The following is a description of a gene set: Mouse Gene Set: GOBP_MULTIVESICULAR_BODY_SORTING_PATHWAY A vesicle-mediated transport process in which transmembrane proteins are ubiquitylated to facilitate their entry into luminal vesicles of multivesicular bodies (MVBs); upon subsequent fusion of MVBs with lysosomes or vacuoles, the cargo proteins are degraded. studied in species Mus musculus, and this is the list of marker genes: Chmp7, Vps28, Chmp4b, Leprot, Vps4a, Chmp1b2, Tmem50b, Chmp5, Chmp3, Vta1, Chmp1a, Sytl4, Exph5, Ubxn6, Sort1, Vps4b, Chmp6, Vps36, Dennd10, Leprotl1, Mvb12a, Rufy4, Stam, Chmp2b, Laptm4b, Chmp2a, Rilp, Chmp4c, Chmp1b, Vps25, Lyst, Rab27b, Vcp, Ptpn23, Rab27a, Snf8, Tmem50a